The following is a description of a gene set: species: Mus musculus from publication Chen Y, Wang X (PMID 31504780) Mouse Gene Set: MIR_1966_5P Genes predicted to be targets of miRBase v22 microRNA mmu_miR_1966_5p in miRDB v6.0 with MirTarget v4 prediction scores > 80 (high confidence targets)., and this is the list of marker genes: Cers2, Adam28, Slc30a5, Numbl, Rgs7bp (NCBI Gene Id 77218), Grhl2, Mtpn, Inpp5b, Crocc2, Smug1, Mei4, Mtcl2, Hoxc6, Limd2, Klrg2, Fkbp4, Cenpm, Lix1l, Sult6b1, Lelp1, Otud4, Dctn1, Srsf1, Fkbp8, Kcnq1, Lrrc59, Eif2ak3, Gigyf2, Prr14l, Il17a, Kcne1, Wiz